The following is a description of a gene set: part of: Miscellaneous transport and binding events Reactome Pathway: Rhesus glycoproteins mediate ammonium transport The Rhesus (Rh) glycoproteins were originally described in human blood cells as potent immunogens. There are three Rh glycoproteins in humans; an erythroid-specific Rh-associated glycoprotein (RhAG) and two non-erythroid Rh glycoproteins, RhBG and RhCG. These proteins are related to ammonium (NH4+) transporters of yeast and bacteria (methylammonium and ammonium permease and ammonium transporter, MEP/Amt) (Nakhoul NL and Hamm LL, 2004; Planelles G, 2007). studied in species Homo sapiens, and this is the list of marker genes: RHAG, RHCG, RHBG